Given this list of marker genes SLC22A16, SLC25A29, SLC16A9, SLC22A1, SLC22A4, SLC6A14, PDZK1, SLC25A20, SLC22A5, here is a description of the gene set: Human Gene Set: GOBP_CARNITINE_TRANSPORT The directed movement of carnitine into, out of or within a cell, or between cells, by means of some agent such as a transporter or pore. Carnitine is a compound that participates in the transfer of acyl groups across the inner mitochondrial membrane. studied in species Homo sapiens